The following is a description of a gene set: The chemical reactions and pathways involving triglyceride, any triester of glycerol. The three fatty acid residues may all be the same or differ in any permutation. Triglycerides are important components of plant oils, animal fats and animal plasma lipoproteins. studied in species Homo sapiens Human Gene Set: GOBP_TRIGLYCERIDE_METABOLIC_PROCESS, and this is the list of marker genes: GNB3, PNPLA1, PTPN11, SLC27A5, TMEM68 (NCBI Gene Id 137695), MFSD2A, APOA4, CTDNEP1, TBL1XR1, GPR82, PIK3CG, PNLIPRP3, THRSP, CAV1, PNPLA3, AGPAT2, LIPA, FBXW7, LIPC, MIR192, APOA2, APOC1, GK2, LPIN2, SLC27A1, CPS1, NKX2-3, PCK2, TMX1, MTTP, SERPINA12, LPL, ATG14, SCARB1, AADAC, PNLIP, SORL1, PLIN5, LIPG, CPT1A, MOGAT1, GPIHBP1, CIDEC, LMF1, APOB, SREBF1, DAGLB (diacylglycerol lipase beta), KAT5, AGMO, FUT1, APOBR, ABHD5, GPX1, INSIG1, PLB1, SEL1L, MIR30C1, MOGAT2, CAV3, TNXB, CIDEB, PNLIPRP2, MOGAT3, DDHD2, MGLL, CNEP1R1, APOE, APOC2, APOA5, LIPE, SIK1, PNPLA4, APOBEC1, LDLR, DGAT2, PANK2, CETP, PCSK9, CAT (NCBI Gene Id 847), GPLD1, APOC3, NR1H3, FITM2, LPIN3, LPIN1, GPAT2, GPAT4, PLAAT3, GPAT3, PCK1, MIR548P, C3, NR1H2, PNPLA5, DGAT1, PNPLA2, SLC22A4, LIPF, MBOAT7 (membrane bound O-acyltransferase domain containing 7), GK, ACSL1, INSIG2, MIR29B1, G6PC1, PNLIPRP1, GPAM, SIRT1, APOF, GK5, APOH, LPGAT1